Given this list of marker genes Cat, Junb, Gabpb1, Mapk10, Fos, Gclc, Mt1, Sod1, Nfkb1, Sp1, Gpx1, Gpx3, Nfix, Sod2, Sod3, Txn2, Cyba, Cyp1a1, Mgst1, Mapk14, Ugt1a1, Nqo1, Gsr, Gstt2, Maoa, Hmox1, Txnrd2, Txnrd1, here is a description of the gene set: Mouse Gene Set: WP_OXIDATIVE_STRESS_RESPONSE Oxidative stress response studied in species Mus musculus